Given this list of marker genes AQP5, MBTPS2, GFI1, CYBA, CCN2, USP48, IDH2 (NCBI Gene Id 3418), ITGB2, NHP2, GYPC, SRP19, TNFRSF1B, TRAF3IP2, CAV1, BTK, TAP1, TP53, NCF1, CDH23, TINF2, WRN, CLEC7A, SPTB, TERT, LYST (lysosomal trafficking regulator), PTPN6, ELANE, F12, PTPN22, RTEL1, DOCK8, PGM3, PDGFB, GNAQ, CD28, RETREG1, ATL3, P4HA2, SLC39A4, LMNA, BMS1, OCRL, SBF2, WAS, PRTN3, HAVCR2, ITGB4 (integrin subunit beta 4), CCT5, IRF5, TREX1, UBA2, CTLA4, PERP, CLPB, NR3C1, MPV17, ATL1, ANTXR2, EPHB4, GBE1, KIF1A, WDR1, TCIRG1, CCR6, STAT3, MLX (MAX dimerization protein MLX), WNK1, STAT4, CYBB, SLC19A1, PEPD, ATRX, PSTPIP1, KIAA0319L, WRAP53, GBA1, AK2, PARN, WIPF1, LAMA3, NFKB1, TERC, USP8, DKC1, RASA1, USB1, LBR, PDGFRB, HLA-B, PIGL, MEFV, DLL4, HLA-DRB1, NOP10, SLC4A1, CTC1, NPM1, KIF11, NOD2, EPB42, NCF2, IKBKG, PLEC, KRT1, SPTA1, COL3A1, NCF4, IDH1, TYMS, IL17RC, HBB, SCN9A, SPTLC1, ANK1, SPTLC2, NGF, TRPV3, TP63, CYBC1, HLA-DPB1, ADA2, KRT10, OTULIN, NOTCH2, IL17RA, BRAF, EPB41, PTH1R, NOTCH3, PROS1, COL1A1, NTRK1, HLA-DPA1, IL12B, IL17F, here is a description of the gene set: Human Gene Set: HP_SKIN_ULCER A discontinuity of the skin exhibiting complete loss of the epidermis and often portions of the dermis and even subcutaneous fat. Skin ulcer species: Homo sapiens